Given this list of marker genes AKT1, IGF1, NAMPT, SIRT1, PRKAB2, PPARGC1A, TP53, MTOR, here is a description of the gene set: Human Gene Set: WP_CALORIC_RESTRICTION_AND_AGING Caloric restriction and aging studied in species Homo sapiens